Given this list of marker genes KCNJ5, KCNJ3, KCNK1, KCNH2, KCNJ9, here is a description of the gene set: A protein complex which is capable of inward rectifier potassium channel activity. species: Homo sapiens Human Gene Set: GOCC_INWARD_RECTIFIER_POTASSIUM_CHANNEL_COMPLEX